Given this list of marker genes PNMA8A, CAND1, ANKRD17, SYNC, FBXO3, PHYHIPL, NUDT4, NCAM1, SS18L1, WSB2, DCAF7, KAT7 (lysine acetyltransferase 7), UBE3A, AHDC1 (AT-hook DNA binding motif containing 1), RBM4B, REEP1, ZMYM2, ELP1, EXOC5, ACSL3, NAA30, SPIRE1, NSD2, RBM8A, HMG20A, CHTOP, IQCK, NUAK1 (NUAK family kinase 1), PTBP2, VPS26B, ZNF84, DMTF1, KLHL42, CLASP2, BSDC1, PHF2, KIDINS220, TEAD1, TMEM237, EIF4ENIF1, FAM8A1, SPAG9, TRAK2, BEX2, BTRC, RABGEF1, IPO7, C2CD5, KIF1B, CSRNP2, REPS1, IPO9, QSER1, ZNF536, MARCHF6, KIF5C, PAIP1, ZFAND5, NPTX1, NAB1, SCARB2, PARP6, CIPC, CEP170, GSTA4, ZFP14, PEG3, RALGAPA1, MECP2, TSPYL4, KAT6B, USP22, NFYA, SPAST, UBE2N, CRNKL1, CORO2B, SUFU, RASA4, UBE2E3, CELF1, AMER2, ZFTA, FBXO30, KMT5B, ZNF529, NISCH, SMAD7, RAN, MTMR9, NFIB, ALS2, CRYBG3, UBE2H, SMAP1, PKNOX1, NLK, BRPF3, NGRN, MAP1B, ASAP2, RABGAP1L, CADM1, GABBR2, ZNF566, PGRMC2, EPC2, ERBB4, CCDC82, ABHD14A, CLCN3, SESN3, MTMR3, RBFOX2, FOXO3 (NCBI Gene Id 2309), PPM1E, ADO, DENND2A, PHC1, CALM1, USP19, DCTN4 (dynactin subunit 4), PAFAH1B2, GSK3B, IGDCC4, ZBTB5, ZNF462, here is a description of the gene set: Human Gene Set: GCM_NCAM1 species: Homo sapiens Neighborhood of NCAM1 Neighborhood of NCAM1 neural cell adhesion molecule 1 in the GCM expression compendium